Given this list of marker genes TEFM, SLC25A33, CHCHD10, PRKAA1, METTL4, MTERF1, TFAM, TFB1M, KANSL1, MTRES1, TFB2M (NCBI Gene Id 64216), MRPL12, POLRMT (NCBI Gene Id 5442), MTERF3, MTERF2, THAP11, KANSL3, MTERF4, TWNK, FOXO3, KAT8, here is a description of the gene set: species: Homo sapiens The synthesis of RNA from a mitochondrial DNA template, usually by a specific mitochondrial RNA polymerase. Human Gene Set: GOBP_MITOCHONDRIAL_TRANSCRIPTION